The following is a description of a gene set: Genes down-regulated in non-neoplastic rectal mucosa samples from patients having cancer associated with ulcerative collitis, compared to those who did not have the cancer. Human Gene Set: WATANABE_ULCERATIVE_COLITIS_WITH_CANCER_DN PURPOSE: Ulcerative colitis (UC) is associated with a high risk of colorectal cancer. To identify genes that could predict the development of cancer in UC, we conducted a DNA microarray analysis using nonneoplastic rectal mucosa of UC patients. EXPERIMENTAL DESIGN: Gene expression in nonneoplastic mucosa of 53 UC patients were examined. Gene expression profiles were examined using human Genome U133 Plus 2.0 gene chip array (Affymetrix). Among 53 UC patients, 10 had UC-associated cancer (UC-Ca group) whereas 43 did not (UC-NonCa group). RESULTS: By comparing gene expression profiles of nonneoplastic rectal mucosae between the UC-Ca and UC-NonCa groups, we could identify genes that were differentially expressed between two groups. The list of discriminating genes included low-density lipoprotein receptor-related protein (LRP5 and LRP6). Previous studies suggested that LRP5 and LRP6 expression promotes cancer cell proliferation and tumorigenesis and are considered as candidate oncogenes. In the present study, both LRP5 and LRP6 showed significantly higher expression in the UC-Ca group, which suggests the importance of these genes in the development of UC-associated colorectal cancers. With the 40 selected discriminating genes, we did class prediction of the development of colorectal neoplasms in UC patients. Using the k-nearest neighbor method and the support vector machine, we could predict the development of UC-associated neoplasms with an accuracy of 86.8% and 98.1%, respectively. CONCLUSIONS: These findings have important implications for the early detection of malignant lesions in UC and may provide directions for future research into the molecular mechanisms of UC-associated cancer. studied in species Homo sapiens from publication Watanabe T, Kobunai T, Toda E, Kanazawa T, Kazama Y, Tanaka J, Tanaka T, Yamamoto Y, Hata K, Kojima T, Yokoyama T, Konishi T, Okayama Y, Sugimoto Y, Oka T, Sasaki S, Ajioka Y, Muto T, Nagawa H (PMID 17255260), and this is the list of marker genes: SAMSN1, GBP5, GBP4, SSH2, SLA, NEDD9, NLRC5, PREX1, CXCR6, LCP2, BTN3A1, CYSLTR1, CNOT6L, IGF2BP3 (insulin like growth factor 2 mRNA binding protein 3), GBP1